Given this list of marker genes Apoa1, Enpp7, Arx (aristaless related homeobox), Cel, Ldlr, Asah2, Apoa4, Aqp1 (aquaporin 1), Pnlip, Npc1, Lep, Apoa2, Cd36, Lima1, Acat2, Abcg8, Abcg5, Npc1l1, Cyp8b1, Lpcat3, here is a description of the gene set: Mouse Gene Set: GOBP_LIPID_DIGESTION The whole of the physical, chemical, and biochemical processes carried out by living organisms to break down ingested lipids into components that may be easily absorbed and directed into metabolism. species: Mus musculus